The following is a description of a gene set: species: Mus musculus The continuous network of membranes encompassing the nuclear outer membrane and the endoplasmic reticulum membrane. Mouse Gene Set: GOCC_NUCLEAR_OUTER_MEMBRANE_ENDOPLASMIC_RETICULUM_MEMBRANE_NETWORK, and this is the list of marker genes: Cyp2c38, Sgk1, Rdh19, Zdhhc16 (zinc finger, DHHC domain containing 16), Tunar, Nat8f7, Jph3, Rps29, Extl3, Cds2, Cyp46a1, Calr3, Sqle, Pi4kb, Armc10, Emc7, Lrrc59, Ptdss2, Gdpd3, Rnf133, Ric3, Erlin1, Minar2, Gosr2, Wfs1 (wolframin ER transmembrane glycoprotein), Sgpp2, Extl2, Nat8f5, Cyp4f39, Hacd4, Alg10b, Oca2, Atp13a4, Shisa2 (shisa family member 2), Atp2a3, Ugt3a2, Vapa (NCBI Gene Id 30960), Tmt1b, Gpam, Emc2, Sel1l2, Emc4, Cyp2c39, Ugt2b5, Stim2, Tex264, Rhbdf1, Ldaf1, Alg14, Ern2, Slc30a5, Bcl2, Iigp1, Selenoi, Rnf186, Fdft1, Cyp4b1 (cytochrome P450, family 4, subfamily b, polypeptide 1), Duoxa1, Cyp2c23, Shh, Tmed1, Cnih1, Atp8b2, Slc27a3, Msmo1, Dpm3 (dolichyl-phosphate mannosyltransferase polypeptide 3), Tmprss3, Or7a40 (olfactory receptor family 7 subfamily A member 40), Smim6, Nus1, Otulinl, Gucy2c, Cers3, Ctdnep1, Cyp7a1, Tmem203, Fads3, Tmem43, Ildr2, Gorasp2, Pomgnt2, Cyp4a10, Cyp2c29 (NCBI Gene Id 13095), Uchl1, Ikbip, Slc51a, Afg2b, Osbpl8, Ubxn8 (UBX domain protein 8), 1810037I17Rik, Lman2l, Atxn3, Klhl14, Derl1, Atg9a, Pml, Canx, Serp1, Card19, Dst, Mboat7, Hacd2, G6pc1, Tmem178, Usp17lb, Zdhhc9, Slc17a3, Gm4841, Slc35b2, Ext2, Cyp2c70 (NCBI Gene Id 226105), Tecr, Neu4, Tmc6, Sec61a1, Disp3, Ifi47, Nup62, Xbp1, Hsp90b1, Gpat4, Cyp2d11, Alox5ap, Furin, Ugt1a7c, Mogat2, Creb3l1, Xk, Atf6, Mia3, Tmem259, Tmbim6, Ier3ip1, Plod2, Srd5a3, Rnf180, Pigf, Tgtp2, Vti1b (vesicle transport through interaction with t-SNAREs 1B), Syne2, Tmem94, Ssr3, Sec16a, Nat8f2, Irag2, Stt3a, Scd2, Pigh, Rdh9, Pdia3, Abcd1, Srl, Ptgis, Rrbp1, Pom121, Faah, Arv1, Tmem39a, Or2c1, Dhrs9, Selenok, Zdhhc4, Pyurf, Tmem258, Pskh1, Mrap, Sec31b, Aph1a, Rab18, Tmem132a, Hhat, Cyp2c40, Sri, Gramd1b, Ficd, Ncstn, Ggcx, Hsd3b7, Sec23b, Pitpnm1, Irgm2, Sppl2c, Pdcd6, Dpagt1, Bnip3, Rnf145, Myorg, Mr1, Ksr1, Hhatl, Trim59, Zdhhc20, Dpy19l4, Vti1a (vesicle transport through interaction with t-SNAREs 1A), Art1, Dolpp1, Stt3b, Pigo, Tmem67, Plpp2, Tpte, Pld6, Parp16, Ptgs1, Tmco1, Acsl6, Plpp6, Lpcat2, Psenen, Ugt2b1, Esyt2, Krtcap2, Sigmar1, Retreg3, Epm2aip1, Hsd11b1, Slc35b3, Mtdh, Nsg1, Tmem147, Tmtc2, Dipk1c, Atp10b, Mmgt1 (membrane magnesium transporter 1), Rnf103, B3gat1, Pigz, Sptssb, Tmem53, Lrit3, Slc35b1, Dgat2l6 (NCBI Gene Id 668257), Elovl1, Mospd2, Alg8, Tmx3, Nat8f4, 9930111J21Rik1, Cyp2d10, Sez6l, Atg2b, Ssr2, Slc18a1, Cyp2b10, Cyp4a12b, Dnajc18, Sec62, Sar1a, Tmem68, Elovl7, Ermp1, Lrba, Ei24, Or5b21, Pja2, Ergic2, Rnf183, Cyp51, Reep6, Creb3l2, Cyb561d2, Dnajc25, Lrrc8b, Soat1, Pemt, Cyb5a, Reep1, Ptgfrn, Use1, Gm5431, Fa2h, Egfr (NCBI Gene Id 13649), Cyp4f14, Aadac, Pnpla6, Stx18, Ltc4s, Osbp, Vcp, Kdelr3, Trex1, Hsd17b3 (NCBI Gene Id 15487), Creb3l4, Rnf144a (ring finger protein 144A), Suco, Alg5, Alg12 (ALG12 alpha-1,6-mannosyltransferase), H2-T3, Tmed4, Atg2a, Mboat1, Ugt2b37, Ergic3, Sppl3, Smpd5, Pld1, Ghrhr, Mapkap1, Gucy2e, Eno1b (NCBI Gene Id 433182), Alg3, Tyro3, Cyp2d9, Ugt3a1, Cyp3a44, Pdzd8, Agpat1 (NCBI Gene Id 55979), Alg1, Sppl2a, Pomk, Anxa7, Tbc1d20, Tgtp1, Ilvbl, Pmel, Dhrs7c, Cyb5r2, Tmem39b, Rint1, Alg6, Mymx, Mgst2, Acer1, Psen2 (NCBI Gene Id 98295), Marchf1, Vps13a, Tmem41b, Lman1, Mboat4, Smpd4, Rp9, Pigyl, Zdhhc2, Tmed9 (transmembrane p24 trafficking protein 9), Kcna2, Gramd1a, Pofut2, Uba1 (NCBI Gene Id 22201), Clmn, Necab3, Stard3, Tmem86a, Spcs1, Rictor, Tmem50b, Pnldc1, Erlin2, Arl6ip5, Napepld, Tlcd3b, Pgrmc1, Slc30a7, Tmx2, Rps28, Lrrc8c, Sec13, Serinc1, Pigk, Klhl41, Selenot, Asph, Nat8f3, Slmap, Mgat4d, F830016B08Rik, Cyp2j5, Nat8, Shisa3, Prkn, Xpo1, Sptlc1, Pigl, Panx2, Tmed6, Chpt1 (NCBI Gene Id 212862), Tmem106c, Saysd1, Sorl1, H2-Q1, Nrros, Rheb, Igtp, Cyp2b19, H2-Q10, Has2, Bicd2, Ssr4, Rab9, Reep3, Tmem98, Duoxa2, Pigt, Camk2b, Pigw, Ube2j1, Atl1, Cyp2c50, Pnpla7, Ptges, Nos1, Gpat3, Ext1, Pomt1, Smim30, Nsdhl (NAD(P) dependent steroid dehydrogenase-like), Nat8f6, Rtcb, Cyp2a5, Cyp39a1, Reep5, Rhbdd1, B3glct, Or10j5, Fads2b, Cyb5r1, Cyp2c55, Acsl3, Acsl4, Mogat1, Zmpste24, Sgpl1, Ccdc47, Xxylt1, Sec22c, Hsd17b12, Tm4sf20, Cers2, Esyt3, Dhh, Agtrap, Rnf26, Stim1, Atp10a, Eef1a2, Tmem208, Rpe65, Unc93b1, Camk2g, Get1, Dhrs7l, Rpn1, Izumo1, Usp17ld, Rnf170, Slc16a11, Tmed2 (transmembrane p24 trafficking protein 2), Tlr7, Extl1, G6pc3, Lrit1, Tmed3, Vps13c, Ptdss1, Sort1, H2-Q2, Tram2, Tmem238l, Zdhhc12, Pla2g4c, Grin1, Ddost, Tmem174, Pgap3, Eno1, Fads2, Gpr37, Dpm2, Jph4, Rdh11, Atp2a1, Ch25h, Awat2, Plpp3, Atp6ap2, Dnajc1, Slc9a6, Drd1, Retsat, Tm7sf2, Zw10, Derl2, Pigc, Ero1a, Lpin1, Sar1b, Aldh3a2, Cln8, Cyp1a2, Epm2a, Dhcr24, Bok, Ebp, Dnajc16, Vapb, Trdn, Grip1, Cds1, Triqk (NCBI Gene Id 208820), Wdr83os, Mgst1, Cyb5rl, Tram1l1 (translocation associated membrane protein 1-like 1), Mtor, Cln3, Fmo1, Cyp2b9, Mctp1, Syne1, Spast, Slc35b4, Dolk, Atp11c, Eva1a, Pld2, Ufl1, Tmem33, Pld5, Dpy19l3, Sec61bl, Rhbdf2, Rnf125, Cybc1, Kdelr1, Zfyve27, Cyp19a1, Rasgrf2, Aqp8, Cherp, Pld4, Sec11c, Frey1, Rnf139, Cyp4f18 (NCBI Gene Id 72054), Tmed10, Rdh1 (NCBI Gene Id 19680), Emc10, Iigp1c, Rab2b, Slc39a7, Derl3, Ubxn4, Cd4, Degs2, Fkbp1b, Nat8l, Sec11a, Atp8b3, Fkbp8, Zfyve1, Gabarapl2, Lrrk2, Gimap3, Slc27a2, Maco1, Hrc, Pgap1, Cyp2a12, Lpgat1, Rtn3, Mrln, Ormdl1, Mbtps1, Mmp27, Hsd3b2 (hydroxy-delta-5-steroid dehydrogenase, 3 beta- and steroid delta-isomerase 2), Lbr, Insig2, Jph1, Marchf2, Becn1, Ano5, Calr4, Hsd3b6, Dipk1a, Rdh16f2, Cyp2r1, Sptlc3, Cyp2j6, Itprip, Abcb6, Sln, Reep4, Insig1, Abhd12b, Soat2, Zdhhc6, Bax, Kdelr2, Scfd1, Lmbrd1, Uba5, Eif2ak3, Faf2, Ero1b, Pcyt1a, Hsd3b5, Rnf19b, Clcn4, Tmbim4, Flrt3, Get3, Scap, Oas1b, Clstn3, Rnf13, Lmbr1l, Itpr3, Fate1, Pi4k2b, Dpy19l1, Slc33a1, Pigb, Zfand2b, Slc22a3, Agpat3, Srebf2, Mblac2, Tmem214 (NCBI Gene Id 97201), Tkt, Cspg5, Ddn, Cnep1r1 (NCBI Gene Id 74731), Arhgap32, Hsd3b4, Porcn, Rdh16, Mboat2, Plpp7, Cyp2u1, Cyp4a12a (NCBI Gene Id 277753), Cyp2s1, Rab1a (RAB1A, member RAS oncogene family), Nploc4, Ankrd13c, Cyp1a1, Tspo2, Slc37a2 (solute carrier family 37 (glycerol-3-phosphate transporter), member 2), Atp13a1, Plaat3, Flrt1, Fmn1, Lss, Rab2a, Pafah2, Traf2, Cant1, Dad1, Lpcat1, Gdpd1, Pigq, Rdh10, Tmem119, Ormdl3, Alg11, Rtp1, Tex2, Panx3, BC016579, Psen1, Degs1, Jagn1, Rtp2, Or8a1, Gulo, Scd4, Hsd17b2, Elovl5 (NCBI Gene Id 68801), Slc37a1, Mmgt2, Gnai3, Bfar, Mbtps2, Tex261, Dse, Cyp1b1, Sgms2, Tmcc3, Mlec (malectin), Rpl27, Nfe2l1, Slc27a5, Atg14, Fkbp2, Lman2, Lctl, Tlr9, Lpin2, Osbpl3, Dpm1, Osbpl6, Trpm1, Ckap4, Hpn, Moxd1, Elovl6, Usp17lc, Cyp3a25, Tapbpl, Pitpnb, Rho, Sec22b, Wls, Tmem63c, Rsad2, Sppl2b, Slc36a2, Pnpt1, Chrm3, Selenos, Caml (calcium modulating ligand), Abhd12, Saraf, Lrrc8d, Fmo5, Rtn1, Ptchd3, Cept1, Upk3a, Cyp2f2, Ormdl2, Slc39a1, Sik2, Ktn1, Ptpn5, Tmem38b, Herpud1, Slc27a4, Vmp1, Magt1, Lclat1 (lysocardiolipin acyltransferase 1), Sec61g (NCBI Gene Id 20335), Ppp1r15a, Grin3b, Mest, Hsd3b3, H2-K1, Mospd1, Nos1ap, Erp44, H2-Q7, Rab10, Pigm, Sec63, Cdkal1, Vma21, Cyp8b1, Slc35d1, Nomo1, Cd74, Cdk5rap3, Cyp2c37, Ube2j2, Flvcr2, Gdpd5, Scd3, Tmem129, Tmed11, Ndrg4, Cyp3a16, Sc5d, Sacm1l, Srd5a1, Calhm1 (calcium homeostasis modulator 1), Bet1, Map3k5, Tor1a, Marchf8, Slc8a3, Serp2, Pkd2 (NCBI Gene Id 77380), Kash5, Tmcc2, Tnpo3, Ryr1, Rtn2, Zdhhc14, Lpcat3, Fzd9, Notch1, Gramd2a, G6pc2, Hpd, Pip4k2b, Atf6b, Atp6ap1, Dhrs7, Rab14, Gimap1, Ugt2b38 (NCBI Gene Id 100559), Agpat5, Vkorc1, Kdsr, Gnrh1, Nat8b-ps, Sec24a, Emc9, Tmem109, Rasgrp1, Sec61a2, Cisd2, Marchf6 (NCBI Gene Id 223455), Reep2, Cyp2d26, Grin2b, Ubqln4, Fitm1 (NCBI Gene Id 68680), Trim13, Abcb9, Gramd4, Pgap2, Acsl1, Ftcd, Clcc1, Osbpl5, Ptgs2, Cnih4, Aup1, Camk2d, Cyp26a1, Bcap31, Shisa5, Stx17, Cyp3a41a, Syne3, Dgat2, Slc30a1, Hacd1, Plod1, Cyp26b1, Arxes2, Anks4b, Dnajb12, Tab1, Alg9, Faxdc2, Tusc3, Cpt1c, Tmed5, Ostc, Man1b1, Gm12185, Rnf5, Cftr, Rdh5, Phtf1, Nutf2-ps1, Zdhhc1, Tmem86b, Ssr1, Hsd17b7, Jph2, Fmn2, Cdipt, Dnajb14, Stard3nl, Traf3ip3, Ncln, Syne4, Esyt1, Creb3l3, Lmf1, Preb, Fitm2, Mmp23, Tmem260, Taar1, Tmem97, Usp17le, Sec23a, Rce1, Tmem35a, Atl3, Acsl5, Yif1b, Dio1, Eif5a, Hmgcr, Eda, Rnf185, Emd, Alg13, Syvn1, Dhdds, Sdr16c5, Rft1, Itpr2, Stimate, Tmem199, Atl2, Slc26a9, Ergic1, Dhcr7, Clptm1l (NCBI Gene Id 218335), Fzd6, Yipf5, Mlana, Rab21, Calr, Fkbp1a, Clstn1 (calsyntenin 1), Selenon, Atp11a, Apoo, Tap2, Bltp2 (bridge-like lipid transfer protein family member 2), Tmc8 (NCBI Gene Id 276788), Dgat1, Ubac2, Txndc11, Ubxn7, Ugt1a9, Nav3, Rps26, Retreg1, Nucb2, Trappc2b, H2-D1, Ddrgk1, Dmpk, Emc6, Edem1, Arl6ip1, Gper1, Creb3, H2-Q4, Cptp, Ubxn1, Sptlc2, Scd1, Pigs, Fut10, H2-Q6, Arxes1, Gpsm1, Itpr1, Sdcbp, Cyp4a14, Cyp17a1, Pik3r1, Mia2, Gpaa1, Pld3, Slc35g1, Nup210, Marchf5, Pigv, Casq1, Gria1 (glutamate receptor, ionotropic, AMPA1 (alpha 1)), Slc37a4 (solute carrier family 37 (glucose-6-phosphate transporter), member 4), Tespa1, Pex16, Tram1, Rnf43, Erg28, Cyp7b1, Zc3h12a, Tmx4, B3galnt2, Nr3c2, Dtnbp1, Dhrs7b, Pigu, Hspa5, Sez6l2, Slc43a1, Icmt, Slc35d3, Abcc12, Sel1l, Fmo2, Atg9b, Hmgcll1 (3-hydroxymethyl-3-methylglutaryl-Coenzyme A lyase-like 1), Tapbp, Ranbp2, Cyp2e1, Sgpp1, Sec16b, Serac1, Cyp3a41b, Piezo1, Rpn2, Spcs2, Lrpprc, Ihh, Fam8a1, Awat1, Bcap29, Fads1, Dcstamp, Tmem151a, Scara3, Emc3, Rab5if, Fut11, Erap1, Gabbr1, Lpcat4, Gramd1c, Hacd3, Map3k7, Gsg1, Cyb5r3, Ebpl, Elapor1, Agpat4, Cers1, Cyp4v3, Tmem14a, Emc8, Samd8, Cers4, Akap6, Atp10d, Irgm1, Ptpn1, Srd5a2, Gba2, Vkorc1l1, C2cd2l, Prss56, Agmo, Tm6sf2, Sec22a, Retreg2, Pln, Nat8f1, Tmx1, Pign, Pnpla8, Mfsd2a, Pigx, P4htm, Nutf2, Cyp3a11, Otof, Abcg1, Emc1, Tapt1, Tlr3, Nup153, Calu, Lman1l, Ost4, Clstn2, P2rx6, Cyp3a13 (cytochrome P450, family 3, subfamily a, polypeptide 13), Myrf (myelin regulatory factor), Slc27a1, Pigg, Plod3, Ubiad1, Srebf1, Elovl2, Yif1a, Bltp1, Rtn4, Vrk2, Ankle2, Cnih2, Aldob, Slc39a13, Slc37a3 (NCBI Gene Id 72144), Myrfl, Svip, Lnpk, Ghitm, Sgms1, Dnajb2, Tmcc1 (NCBI Gene Id 330401), Fxyd3, Panx1 (NCBI Gene Id 55991), Steep1, Fmo4, Frrs1l, Casp4, Tmem38a, Elovl3, Pgs1, Stbd1, Tbxas1, B2m (NCBI Gene Id 12010), Spcs3, Por, Peds1, Dlg1, Cers5, H13, Bnip1 (NCBI Gene Id 76517), Spink5 (serine peptidase inhibitor, Kazal type 5), Acer3, Yipf7, Sting1, Alg2, Fmo3, Rnf121, Hmox1, Bsg, Abcd4, Zdhhc22, Dnajc14, Mogs, Bscl2, Srpra, Hmox2, Cideb, Abca17, Ugt1a1, Pigp, H2-T23, Ryr2, Elovl4, Sts, Nox4, Strit1, Ugt1a2, Slc27a6, Grm6, Rnf26rt, Mrap2, Atp2a2, Dio2, Amfr, Snca, Cers6, Lrrc8e (NCBI Gene Id 97482), Ryr3, Agpat2, Hsd3b1, Aqp11, Znrf4, Cyp4x1, Gm12250, Tmem170, Jkamp, Clgn, Cyp2a4 (cytochrome P450, family 2, subfamily a, polypeptide 4), Tap1, Lmf2, Flrt2, Sptssa (NCBI Gene Id 66149), Lrat, Piga (NCBI Gene Id 18700), Ephx1, Usp19, Pkmyt1, Eif5a2, Sec31a, Ugt1a6a, Smim14 (NCBI Gene Id 71403), Ufd1, Faf1, Jsrp1, Dipk1b, Pomt2, Srprb, Sec61b, Mapk8ip1, Cyp21a1, Slc10a7, Ern1, Surf4, Usp17la, Cyp2c54, Ttyh1